Given this list of marker genes HMGA2, DAAM1, CYTH1, PDGFC, JARID2, GASK1B, JUNB, C3orf52 (NCBI Gene Id 79669), FHOD3 (formin homology 2 domain containing 3), EPHB2, CALD1 (NCBI Gene Id 800), KCNJ15, PTPRK, IL11, PODXL, CDK14, TP53I3, CDH2, MMP9, GNG11, TPST2, TGFB1 (NCBI Gene Id 7040), GADD45B, KCNMA1, DIXDC1, VCAN, MAP1LC3B, JUN, NRIP3, RGS4, ANKLE2, EML1, MAGED2, ELK3, ADAMTS6, BMAL1, TIMP2, LOX, HMOX1, GREM1, HS3ST3B1 (NCBI Gene Id 9953), MMP10, DSE, MN1, SCG2, ITGA5, HTRA1, MFAP2, COL6A3, PDGFA, TMCC1, PLEK2, SERPINE2, VIM, MAF, BPGM, TNFAIP6 (NCBI Gene Id 7130), SPHK1, TGM2, RUNX2, COL5A1 (collagen type V alpha 1 chain), SLCO2A1, SKIL, MMP2, LAMC2, DOCK4, FAM114A1 (NCBI Gene Id 92689), SMURF2, DLC1, CCN2, MYO10, TBX3, SNAI2, ZNF365, BMPR2, ABCA1, TAGLN, LBH, ARFGAP1, PTHLH, ADAM12, COL5A2, PID1, SEMA3C, RFTN1, PSMD2, SACS, ADAM19, NCF2 (neutrophil cytosolic factor 2), STC1, THBS1, NKX3-1, FN1, TGFBI, ALOX5AP (arachidonate 5-lipoxygenase activating protein), WNT5B, GALNT10, PRR5L, PXDC1, TCF4, PTPN21, PEA15, COL4A1, DACT1, AMIGO2, MBOAT2, BMP1, MMP1, ACTN1, XYLT1, ETS2, CHST11, ACKR3, TUBA1A, SCG5, NT5E, ARHGEF40, GLIPR1, ITGB3, AP1S2, SPDL1, PMEPA1, LUM, SRRD, BHLHE40, FSTL3, SPARC, SIK1, COL3A1, TGFB1I1, DUSP10, CRLF1, TPM4, LMCD1, COL4A2, TNS1, FERMT2, POSTN, CDH11, INHBA, MICAL2, KDELR3, COL1A1, GAL, CD59, MATN3, INPP4B, PLAUR, SLN, APBB2, GRB10, TFPI2, NEDD9, SPOCK1, SLC22A4, BMP2, TAGLN2, KLF7, COL7A1, SRPX, DHRS2, MRC2, JAG1, HS3ST3A1, SERPINE1, SLC26A2, VGLL3, GFPT2, TPM1, NUAK1, PIK3CD, PALLD, FBN1, MYL9, TUFT1, RALA, NREP, FOXD1, ANGPTL4, WNT5A, HRH1, SMAD7, TPST1, IGFBP7, LARP6, AKT3, IGFBP5, HSF2BP, CHRNA9, PDLIM7 (PDZ and LIM domain 7), TUBA4A, VEGFC, here is a description of the gene set: species: Homo sapiens Genes up-regulated in the epithelial-mesenchymal transition (EMT) upon transforming growth factor beta (TGFb) stimulation derived from multiple datasets by combining results from an integrative approach and a product of ranks meta-analysis approach. from publication Foroutan M, Cursons J, Hediyeh-Zadeh S, Thompson EW, Davis MJ (PMID 28119430) Human Gene Set: FOROUTAN_TGFB_EMT_UP Most cancer deaths are due to metastasis, and epithelial-to-mesenchymal transition (EMT) plays a central role in driving cancer cell metastasis. EMT is induced by different stimuli, leading to different signaling patterns and therapeutic responses. TGF_ is one of the best-studied drivers of EMT, and many drugs are available to target this signaling pathway. A comprehensive bioinformatics approach was employed to derive a signature for TGF_-induced EMT which can be used to score TGF_-driven EMT in cells and clinical specimens. Multiple datasets were used to derive the signature using three approaches: by integrating the datasets prior to identifying EMT genes, by first identifying EMT genes from individual datasets and then combining them using a meta-analysis (product of ranks) approach, and by combining inferences from the first two approaches.